The following is a description of a gene set: from publication Yosef N, Shalek AK, Gaublomme JT, Jin H, Lee Y, Awasthi A, Wu C, Karwacz K, Xiao S, Jorgolli M, Gennert D, Satija R, Shakya A, Lu DY, Trombetta JJ, Pillai MR, Ratcliffe PJ, Coleman ML, Bix M, Tantin D, Park H, Kuchroo VK, Regev A (PMID 23467089) Human Gene Set: GSE43955_10H_VS_60H_ACT_CD4_TCELL_WITH_TGFB_IL6_DN Despite their enormous importance, the molecular circuits that control the differentiation of Th17 cells remain largely unknown. Recent studies have reconstructed regulatory networks in mammalian cells, but have focused on short-term responses and relied on perturbation approaches that cannot be applied to primary T cells. Here, we develop a systematic strategy – combining transcriptional profiling at high temporal resolution, novel computational algorithms, and innovative nanowire-based tools for performing gene perturbations in primary T cells – to derive and experimentally validate a temporal model of the dynamic regulatory network that controls Th17 differentiation. The network is arranged into two self-reinforcing and mutually antagonistic modules that either suppress or promote Th17 differentiation. The two modules contain 12 novel regulators with no previous implication in Th17 differentiation, which may be essential to maintain the appropriate balance of Th17 and other CD4+ T cell subsets. Overall, our study identifies and validates 39 regulatory factors that are embedded within a comprehensive temporal network and identifies novel drug targets and organizational principles for the differentiation of Th17 cells. Genes down-regulated in CD4 T helper cells Th17 treated with TGFB1 and IL6: 10h versus 60h. studied in species Homo sapiens, and this is the list of marker genes: CCN1, C1QTNF1, SLC35E4, NKX2-6, RAD51D, C2, STT3B, TAC3, ELK3, DUSP1, GPR162, TAGLN, H1-5, WLS, ID2, CSNK2B (NCBI Gene Id 257616), COL9A3, COMMD9, OAZ2, SBDS, HSD17B2, CCNT1, INSRR, DPCD, CDH9, RNF145, PABPC4, RNF123, UBAC2, SIPA1L2, KCNQ1, DDIT4, S100A6, DLG3, RAB33B, GNGT2, PRUNE1, GP9, PCBP4, F3, AGRN, MAP3K1, TNFSF9, MVK, CD72, RECK, CDH8, ZMYND11, NDRG1, BMPR1B, THBS2, COLGALT1, CDKN1C, CSRP1, ESRP2, HAL, VAMP1, FOLR1, COL1A2, PHLDA1, HAS2, TPD52L1, LIPA, CEP250, ATP7A (NCBI Gene Id 613259), EMP1, CYTIP, SNX9, COL18A1, SYT17, PPP4R2, LIMD2, IL7R, MCL1, SLC1A2, HIVEP1, KCNN4, SDHB, MIA, NYNRIN, BSN, NDUFA2, GAB1, MMP15, COL1A1, PSMD2, ADPRM, UBE2C, RXRG, RESP18, SCHIP1, CLN3 (NCBI Gene Id 1201), ENY2, CLK2, ZIC2, AIF1, ODC1, RCAN1, GTF3A, TPBG (trophoblast glycoprotein), VCAM1, LPIN2, SNHG6, TENM1, ANXA2, SOAT2, CACNB3 (NCBI Gene Id 784), FKBP7 (NCBI Gene Id 51661), STAU1, MESD, E2F5 (E2F transcription factor 5), REXO1, BHLHE40, IFI27L2, MAPK6, P2RX7, HGSNAT, ARFGEF1, PGRMC2, SMAD5, BCL6, LY6E, MYL2, JARID2 (jumonji and AT-rich interaction domain containing 2), CBFB, S100A11, CNOT7, NUPR1 (nuclear protein 1, transcriptional regulator), INHBA, PLAUR, IFT70B, TIMP3, OLR1, ANXA7, HPGD, IL11, OMP, CYFIP1, HK2, GHITM, MRPL48, TSPAN6, MGP, GGH, ZFP36L2, PENK, COMMD3, LSM4, H1-3, PMS2, IGF2BP2, GPX2, ADGRE1, ADORA2B, CR2, PON1, SP4, PRL, MXI1 (NCBI Gene Id 4601), AKR1B15, HDAC3, TNFRSF11B, B4GALT6, ZNF841, MME, CD93, LANCL1, BASP1, IKZF2, MX2, WWTR1, IRF1, TFPI2, KRT6A, HPCAL1, AQP2, AEBP1, EDN1, ADAM8, PLS3, PTPRCAP, CAT, KCNQ2, EVL (Enah/Vasp-like), MYH10, TUBB2A, SLC22A17, ZEB1, MELTF, PTCH1, CDS2, SPOUT1, MDM2, RBM6, TAF11, APEX1, MATN2 (NCBI Gene Id 4147), GABBR1, DUSP6 (dual specificity phosphatase 6), NT5DC3